The following is a description of a gene set: species: Homo sapiens FLT3 signaling in disease Human Gene Set: REACTOME_FLT3_SIGNALING_IN_DISEASE, and this is the list of marker genes: ETV6, PIK3CA, PIM1 (Pim-1 proto-oncogene, serine/threonine kinase), MYO18A, TRIP11, STAT5A, UBA52, GRB2, ZMYM2, GAB2, BCL2L1, KRAS, UBC (ubiquitin C), SOS1, PTPN11, FLT3, CDKN1A, FLT3LG, STAT5B, PIK3R1, SPTBN1, CBL, HRAS, RPS27A, NRAS, NOX4, GOLGB1, UBB